The following is a description of a gene set: Human Gene Set: WP_FOCAL_ADHESION Focal adhesion studied in species Homo sapiens, and this is the list of marker genes: TNN, TNK2, MYL5, VEGFD, COL4A6, LAMB3, COL6A2, ITGA6, AKT3, HCK, ACTN1, BLK, SRMS, ZYX, MAPK3, THBS1, COL4A1, LAMB2, PARVB, ELK1, FLNA, RAP1B, VAV2, PPP1R12B, ITGB7, ITGB3, PTEN, ITGA5, VAV1, CCND3, MYL12A, FGR, RAC3, MYL2, CAV3, PIK3CD, TNK1, ITGA7, SRC, PGF, BIRC2, PRKCA, ERBB2, COL1A1, THBS2, CAV2, FLT1, PDGFA, SHC1, TXK, KDR, SOS1, GRB2, PPP1R12C, PIK3CA (phosphatidylinositol-4,5-bisphosphate 3-kinase catalytic subunit alpha), MAP2K1 (mitogen-activated protein kinase kinase 1), RAPGEF1, SHC2, PARVG, JUN, ITGAV, ITGB6, PAK1, IBSP, LAMC1, ACTN4, PIK3CB, LAMA3 (NCBI Gene Id 3909), ITGA9, PDGFB, COL4A2, CAV1, VEGFB, CCND1 (cyclin D1), ITGA3, BCL2, PAK6, CRKL, IGF1, CTNNB1, PIK3R3, SHC3, ILK, CHAD, MYL11, LAMB1, BCAR1, ITGB5, ITGA2 (integrin subunit alpha 2), VEGFA, XIAP, ITGA1, AKT2, FN1, CRK, MAPK1, VEGFC, HGF, PAK3, HRAS, MAPK10, FYN, PPP1CC, MYLK, PARVA, BRAF, RAC2, VTN (vitronectin), IGF1R, MET, MYL10, TLN1, EGF, PAK2, RELN, MYLK3, LAMA1, GSK3B, TNXB, PIK3R1, LAMC2, PXN, PDGFRB, BIRC3, RASGRF1, ROCK1, ITGB1, COL4A4, CCND2, AKT1, PDPK1, MYL9 (NCBI Gene Id 10398), PTK2, PIP5K1C, MYL12B, ITGA11 (NCBI Gene Id 22801), ACTG1 (NCBI Gene Id 71), SHC4, PPP1CB, PPP1R12A, STYK1, FLNC (filamin C), PRKCG, SPP1, ACTB, PDGFD, COL1A2, VAV3, ITGA8, PIK3R2, RAP1A, MAPK9, THBS4, RHOA, EMP2 (NCBI Gene Id 2013), EGFR, THBS3, VWF, TLN2, PAK4 (NCBI Gene Id 115291), FLNB, PDGFC (NCBI Gene Id 56034), ARHGAP5, RAF1, TNC (NCBI Gene Id 3371), DIAPH1, MYLK2, LAMA5, ITGA10, COL2A1, DOCK1, MYL7 (myosin light chain 7), ROCK2, LAMC3, TESK2, RAC1, PPP1CA, ITGA2B, PRKCB, BUB1B-PAK6, PTK6, COMP, MAPK8, LAMA2, CDC42, ITGA4, VCL, ARHGAP35 (NCBI Gene Id 79266), COL5A3, VASP, TNR, ITGB4, CAPN2, PDGFRA, ITGB8, LAMA4, MYLK4, COL5A2, BAD